Given this list of marker genes TMSB15A, HTR4, INHBB, ALDH1A1 (NCBI Gene Id 96075), TLE1, LHX2, RTN1, LARGE1, ENO2, RIMS3, DUSP5, KLHDC3, ATP6V1D, TACC2, GFPT2, TMCC2, KRT86, DLG4, EEF1A2, ATP1B1, ROR1, CDH22, DIRAS3, PALM, ABLIM1, CNP, ADH1A, APOC4, APBB1, HBB, GNG4, MYO10, BRD4 (NCBI Gene Id 90616), NEBL, KCNJ4, NAB2, NAP1L3, PDE4B, RHOB, PLCH2, GPC3, RNASE1, CHRNB1, SERPINI1, CDK18, THBS4, MTMR9, OMG, STMN2, FZR1, CACNA2D2, TSPYL2, MLLT11, CX3CR1, FGFR1, TBR1, VSNL1, LIPA, TIMM17B, AANAT, GABRB3, SCG2, EXD2, PLP1, INSM1 (INSM transcriptional repressor 1), AKR1C1, EPN2, SPARCL1, FGFR2, CFAP410, SGCE, STAT2, PRAME, AHDC1, CKMT1B, DYNC1I1, MAPK10, APC2, SCN1B, DPP6, TCEAL4, RBMS3, NCAM1, PTP4A3, GPRC5B, CA2, WFDC2, DLK1 (delta like non-canonical Notch ligand 1), FGB, BMERB1, RNF144A, HTRA1, ARMCX2, ATOSB, TSPYL4, RGS7, GABRG2, PCP4, PLEKHB1, PDE2A, FRZB, PKIA, COL9A2, PCSK1, NECAB3, RSBN1, NEURL1, BICD1, GET1, ATP9A, GAGE12F, SSTR2, LMO4, PCBP4, MAGI2, FOS, ELF3, AGT, ANGPT1, SETBP1, ALDH7A1, QPCT, FAT1, ATP6V1G2, KIF3A, BAIAP3 (BAI1 associated protein 3), SPTBN2, PHLDA1, FAM107A, TENM4, LPL, GJA1, DUSP8, ITPKA, NPY, NTRK2, SCAMP5, TNC, SYNE1, PTN, SOX10, ABCC8, LDOC1, SMARCD3, ST18, KCTD17, SCHIP1, COX7A1, HSPA2 (heat shock protein family A (Hsp70) member 2), NRG2, ACD, PTPRN, PARD6A, LAMA2, VCAN, MAL, ABLIM3, ALDH4A1, CHL1, CA11, ABAT, ITGA6, APOC1, KIF5C, RASSF2, DCLK1, RND3, EPB41L3, SH3GL3, CACNG3, RGS1, LY6H, COL9A3, RHBDL1, PTPRO, SFRP1, DPYSL3, FAM131A, B4GAT1, AAK1, SELENOP, RAB31, RIMS2 (regulating synaptic membrane exocytosis 2), FXYD1 (NCBI Gene Id 5348), GAD1, PER1, CDH11, FEZ1, ATP6V0A1, ELAC2, NCALD, POMZP3, PDGFRA, SERPINA1, RGS5, SLC39A6, ADIRF, HRAS, DVL1, GPRASP1, GRIK5, TBC1D9, GUCY1B1, KLK6, ANOS1, IFI27, DNAJB2, SOX4, ACSL6, MYRF, RAB11B, GBF1, CCK (NCBI Gene Id 885), INPP1, ZIC1, SNRK, IQSEC1, MTHFR, PARM1, IFIT1, CRYM, STX1A, TM7SF2, IGFBP6, LMO2 (LIM domain only 2), WASF3, SYNGR1, FKBP1B, CITED1, NR1D1, TRIM2, CHST15, ZBTB18, MAPK8IP2, TUBGCP4, ACTL6B, RCAN2, TRO, UBL3, CRYAB, PTPRN2, WIF1, ZBTB16, NEFL, UBXN1, NUPR1, SPOCK2, PFKFB4, ABCA3, SH3BGR, POLR2J, FABP7, UBE2D1, GABBR2, PPL, CHGA, TRIM23, NHERF1, NEO1, TFAP2B, TLE2, SNAP25, EPHX1, PPP3CA, TRPC4AP, STOML1, IGFBP3, RELN, EPAS1, MPP3, AQP4, PAX6, ITGA7, MAT1A, KIF21B, S100B, DBN1, KAT6B, BIN1, SYT5, RASL10A, SCN2B, TNF, PPP4R2, GPX3, KCNK1, NPTX1, PTPRD, CARTPT, GSTM1, APOE, MACIR, MAP7, SERPINA3, SNPH, SOD3, ANK3, ITPR1, ZBTB20, MDK, ARHGEF4, FZD7, SPHK2, MAPRE2, CACNA1A, EFS, CLIP3, CHST1, FEV, NEFM, OLFM1, SNCG (synuclein gamma), CADM1, TRPM2, SLC23A2, SLC2A3, MAOB, SOX9, PSG7, KYAT1, PSPHP1, CALB2, ASIC1, PRPF19, PRPF6, KMT2A, EFNA2, HPR, SLC22A18AS, NNAT, CDH18 (cadherin 18), CEP135, TMEM47, RYR3, PHYHIP, GPM6A, SPP1, MYLK, RALGPS1, CHN2, ALB, RAC3, CBLN1, CELF2, CLDN10, CORT, MYH11, LDB2, THBS2, ELAVL2, PTGDS, PTPRZ1, DKK4, EPHA4, GNAO1, CELSR3, NOVA1, CKB, BCAS1, CCND2, ENPP2, SIX6, CACNB3, MBP, RGS4, RUNX1T1, ALCAM, CRABP1, GSTA4, FADS2, RPS4Y1, PEG10, GRIN1, GJB1, FOXO4, DDX3Y, GRIK1, MTUS1, CGA, ST3GAL5, CPE, TSPAN8, WDR7, SEPTIN5, CTSF, PLXNB1, CEL, PRKACB, TF, GABBR1, TUSC3, FOLR2, PRKCZ, STXBP1, PCK1, NCAN, CORO1A, FOXG1, MEGF9, DDX17, ZIC2 (Zic family member 2), NRGN, SCRN1, INSIG1, SORBS2, PTK2B, QDPR, CLDN5, GNG7, HAGH, NRXN1, SLC17A7, SST, PRB4, SV2B, MEF2C, MAOA, NECAP1, GADD45G, TMX4, CALB1, PKD1, RND1, STK39, SV2A, SLC6A3, MLC1, MTSS1, COL6A2, FGF9, ITM2A, RUNDC3A, ARNT2, ELAVL4, TRIM9, TIMP3, APLP1, PRKCB, SLC1A6, C1QB, CNTNAP2, SNAP91, FGFR3, DCX, ARC, ATP2B2, GAL, EDA, DPYSL4, PRSS2, KCNA5, NFYC, CSRP2, PITPNB, DBP (D-box binding PAR bZIP transcription factor), CDKN1A, STMN1, ELMO1, AMPH, CBX6, PLCB1, ACSL1, ATP1B2 (ATPase Na+/K+ transporting subunit beta 2), CDH2, SNCB, GLRB, CHGB, NID2, ABCC5, CLEC3B, UCHL1, ALDH1A3 (NCBI Gene Id 90476), RPH3A, ARHGDIG, SULT4A1, MT1G, SYT1, SLC1A3, EVI2A, ST6GALNAC4, CYB5R1, TSPAN7, PCDH9, L1CAM, PLAAT3, ORM2, CA12, AQP1, MXD4, SRPX, H2BC21, DTNB, HSPA13, VGF, DMBT1, LGR5, RBP1, LZTS3, CABP1, BTBD3, SPOCK1, PENK, CRMP1, EDNRB, PSD, C3, GRIA2, HMOX1, GNG12, EFNB3, F3, DGCR2, APOD, SCO2, TAGLN3, CBR1, BCL11A, GALR3, DNM1 (dynamin 1), SLIT1, KRT4, AMT, MAPT, KHDRBS3, FAT2, CSPG5, CSH2, PLXNA2, MEIS2, SCG5, NOVA2, FBXL7, MAP2, GAP43, APBA2, PDE8B, IGFBP2 (insulin like growth factor binding protein 2), THRA, CDH4, NR4A1, TYRO3, GATM, CD24, PAX4, here is a description of the gene set: Genes in the cancer module 100. Human Gene Set: MODULE_100 studied in species Homo sapiens